The following is a description of a gene set: Any process that activates or increases the frequency, rate or extent of gamma-delta T cell differentiation. Human Gene Set: GOBP_POSITIVE_REGULATION_OF_GAMMA_DELTA_T_CELL_DIFFERENTIATION species: Homo sapiens, and this is the list of marker genes: SYK, NCKAP1L, STAT5B, STAT5A, LCK, PTPRC, LEF1, SOX4, SOX13